Given this list of marker genes PRG2, ARHGDIB, SLC25A5 (NCBI Gene Id 292), CNN2, NPM1, SFT2D1 (NCBI Gene Id 113402), TMEM60, PWP1, KPNA2, HOXA9, CALM1, RPL6, EZH2, PTPN12, KDM4C (lysine demethylase 4C), here is a description of the gene set: Genes down-regulated in long term hematopoietic stem cells (LT-HSC) compared to multipotent progenitor (MPP) cells. studied in species Mus musculus Human Gene Set: PARK_HSC_VS_MULTIPOTENT_PROGENITORS_DN Hematopoietic stem cells (HSCs) have self-renewal capacity and multilineage developmental potentials. The molecular mechanisms that control the self-renewal of HSCs are still largely unknown. Here, a systematic approach using bioinformatics and array hybridization techniques to analyze gene expression profiles in HSCs is described. To enrich mRNAs predominantly expressed in uncommitted cell lineages, 54 000 cDNA clones generated from a highly enriched population of HSCs and a mixed population of stem and early multipotent progenitor (MPP) cells were arrayed on nylon membranes (macroarray or high-density array), and subtracted with cDNA probes derived from mature lineage cells including spleen, thymus, and bone marrow. Five thousand cDNA clones with very low hybridization signals were selected for sequencing and further analysis using microarrays on glass slides. Two populations of cells, HSCs and MPP cells, were compared for differential gene expression using microarray analysis. HSCs have the ability to self-renew, while MPP cells have lost the capacity for self-renewal. A large number of genes that were differentially expressed by enriched populations of HSCs and MPP cells were identified. These included transcription factors, signaling molecules, and previously unknown genes. from publication Park IK, He Y, Lin F, Laerum OD, Tian Q, Bumgarner R, Klug CA, Li K, Kuhr C, Doyle MJ, Xie T, Schummer M, Sun Y, Goldsmith A, Clarke MF, Weissman IL, Hood L, Li L (PMID 11781229)